The following is a description of a gene set: A ribonuclease P complex located in the nucleolus of a eukaryotic cell, where it catalyzes the 5' endonucleolytic cleavage of precursor tRNAs to yield mature tRNAs. Eukaryotic nucleolar ribonuclease P complexes generally contain a single RNA molecule that is necessary but not sufficient for catalysis, and several protein molecules. studied in species Homo sapiens Human Gene Set: GOCC_NUCLEOLAR_RIBONUCLEASE_P_COMPLEX, and this is the list of marker genes: POP5, RPP21, POP1, RPP38, POP7, RPP30, RPP40